The following is a description of a gene set: Genes having at least one occurence of the motif CTATGCA in their 3' untranslated region. The motif represents putative target (that is, seed match) of human mature miRNA hsa-miR-153 (v7.1 miRBase). species: Homo sapiens Human Gene Set: CTATGCA_MIR153, and this is the list of marker genes: RASA1, RPL22, GCA, DACH1, BSN, PLEKHA3, SYT1, BPTF, NAV2, PRDM2 (NCBI Gene Id 82680), SOX11, NEUROD6, KLF5, GFPT2, MFN1, ARPP19, TTYH3, XKR4, ACTN4 (NCBI Gene Id 81), MYCBP, YBX1 (Y-box binding protein 1), RNF26, TRAK2, NFE2L2, BPNT1, CMIP, CDK13, MFAP3L, TNRC6B, DUSP3, CAMK2G, NPTN, FURIN, RPS6KB1, PAX2 (NCBI Gene Id 5076), CREBBP, TESK2, CREM, KCTD5, KCNA6, SLC9A6, SRSF10, EXT1, RGS7BP, TAF5, FAM171A1, CLTC, GLCCI1, UXS1 (UDP-glucuronate decarboxylase 1), DDIT4, SRC (SRC proto-oncogene, non-receptor tyrosine kinase), INHBB, TP53INP1, ZCCHC14, EPHA4, MYB, CIB2, ZCCHC2, GMCL2, CKAP4, DCP2, ITSN2, ADGRA2, POU4F1, ZBTB2, PLCB1, NUDT4, GALNT7, KDSR (NCBI Gene Id 2531), ZNF609, DPYSL5, KBTBD8, CITED2, ZNF518A, MKX, ZNRF2, EFNA3, CYFIP2, ARHGAP5, ADAM19, TFDP2, CELF2, C6orf120, CNN3, TMEM168, SCRT2, HEY2, ING2, OSBPL6, SIGMAR1, AKAP6, SERTAD2, KLHL3 (kelch like family member 3), DMD, MAPK1IP1L, KLF13, NAA50, RYR2, TAGLN3, APP, GRB2, TES, MIER3, MORC3, LAMP1, UBR1, FGFR2, SLCO5A1, TBC1D19, MAT2A (methionine adenosyltransferase 2A), TP53INP2, ORC2, UBE2W, WIPF1, SLC1A2, RYR3, SNCA, GNAI3, PDS5A, UBA2, FEM1C, SCML2, PRR16, KCND1, SPHK2, SH3BP4, SGK3, FGF7P6, MAPK4, KANSL1 (KAT8 regulatory NSL complex subunit 1), SMARCD2, APC, FOXO1, LRP12, BTBD7, QKI, ROBO2, CBFB, HLCS, PPM1D, FBXL3, C9orf40, SETD7, EPC1, CTDSPL2, SLC10A3, AUTS2, NEUROD1, ARK2C, SNAP25, KCTD6, EFNB2, ARHGAP6, PPP3CA, NUP58, ASB7, HNRNPA1, TENT4A, SEPTIN11, SUN2, JAG1, DLX1, ROCK2, BMPR2, SLC4A4, LAMC1, CUX2, ZDHHC1, WIPF2, DLGAP2, RASSF4, RAI14, SFPQ, CAMKK2, YIPF2, APLP2, FLRT2, PTCH1, WDR26, MCL1, ANK1, SLC30A3, VAMP2, TPCN1, CLCN5, LARP1, ZNFX1, CAPN15, TGFBR2, DOT1L, MYCL, LDOC1, CCSER2, AGO1, PIP5K1C, SEMA4G, OTUD4, PDLIM7, CANX, ASXL1, FAM210B, MAGI1, CELF6, USP28, ZFPM2, KMT2D, ERO1B, SIX4, PIK3R1, MKNK2, SPTSSB, PPARGC1A (PPARG coactivator 1 alpha), ARL4A (ADP ribosylation factor like GTPase 4A), ARF1, CADM2, ZFYVE9, RABGAP1, ZNF385C